Given this list of marker genes H4c8, H2aj, Smarca5, Rtel1, Cenpm, Cenpp, H4c12, H2ac22, H2bc4, Dna2, Cdk2, Ppp6c, H2bc22, H2bc13 (H2B clustered histone 13), Daxx, Rfc1, H4c11, Rpa3, Nop10, Oip5, Ten1 (TEN1 telomerase capping complex subunit), H4c14, Rfc3, Rpa1, H4c2, Cenpc1, H2bc3, Terf2ip, H4c3, Mis18a, Rfc4, H2ab1 (H2A.B variant histone 1), Ccna1 (cyclin A1), Rbbp4, Gar1, H2ac8, Pola2, H2ac13, Cenpx, H4c6 (NCBI Gene Id 319157), Rfc2, Pcna, H2bc12, H3f3a, H2ac18 (H2A clustered histone 18), Wrn, Pold3, Rbbp7, Ruvbl1, Hjurp, Lig1, Blm, H2ac15, H2ac4 (H2A clustered histone 4), H2ac24, H2bc26, H2ac7, H3f4, Pif1, H4c9, Chtf8, Fen1, H2bc14, Rsf1, H4c18, H2bc1, Pold4, Pold1, H2ab2, Pola1, H2ac12, H2ax, Cenpl, Cenpo, H4c17, Ctc1, H2bc24, H4c1, H2bc15, Ccna2, Ppp6r3, Cenpk, Shq1, Wrap53, H2ab3, Cenpa, H2ac6, Chtf18, Stn1, H4c16, H2bc9, Npm1, Tert, Pold2 (NCBI Gene Id 18972), H2bc8, Mis18bp1, Prim1, Pot1a, H2ac20, Cenps, Cenph, Terf1, H4c4, H2ac19, H2ac23, Cenpu, Ankrd28, H2bc7, H2bc23, Rpa2, Cenpq, H2bc11, Prim2, H2bc21, Nhp2, Acd, H2ac11, Dkc1, Atrx, Terf2, Cenpn, Rfc5, H2ac10, Cenpw, Cenpt, H2az2 (H2A.Z histone variant 2), H3f3b, H2bc6, Cenpi, Dscc1, Itgb3bp, here is a description of the gene set: species: Mus musculus Chromosome Maintenance Mouse Gene Set: REACTOME_CHROMOSOME_MAINTENANCE